The following is a description of a gene set: from publication Baranek T, Manh TP, Alexandre Y, Maqbool MA, Cabeza JZ, Tomasello E, Crozat K, Bessou G, Zucchini N, Robbins SH, Vivier E, Kalinke U, Ferrier P, Dalod M (PMID 23084923) studied in species Homo sapiens Human Gene Set: GSE39556_UNTREATED_VS_3H_POLYIC_INJ_MOUSE_NK_CELL_DN Genes down-regulated in NK cells: untreated versus poly(IC). The injection of the pathogen-associated molecular pattern Polyinosinic-polycytidylic acid (poly(I:C)) leads to the activation of various immune cells, including dendritic cells (DCs) and Natural Killer (NK) cells. This activation is due to different innate cytokines produced early after injection, in particular IFN-I. The objective of the study was to compare the pattern of expression of IFN-I stimulated genes between DC and NK cells. The project focused on a specific subset of conventional DC, CD8a DC, which responsiveness to IFN-I determines the capacity to activate CD8 T cells by cross-presentation of exogenous antigens. To identify the responses to IFN-I selectively induced in CD8a+ DC, we compared their gene expression profile to that of NK cells, using gene chips, before and after poly(I:C) stimulation., and this is the list of marker genes: CSNK1E, H2BC5, SOCS2, ATOSB, MYRF, OAS2, MED13L, H1-2, ITPR1, HLX, SERPING1, TTBK2, SPINK1, GNS, S1PR4, KRT12, STARD3, ZMYM2, HCP5, BAZ2B, RYBP, WASHC4, ATP2B4, ST3GAL6, SIAH2, TOGARAM1, RANBP6, PXDN, LILRB2 (leukocyte immunoglobulin like receptor B2), NPAS3, KLF10, MPPED2, ACSL1, CD99, CD34, KHNYN, HMCES, PSD3, CEP68, ERG, RFX5 (regulatory factor X5), YBX3, SV2A, PGLYRP1, IQGAP2, EIF1, FBLN5 (NCBI Gene Id 11268), FOXJ3, SORL1, MXI1 (MAX interactor 1, dimerization protein), WSB1, TNFAIP1, ITGA5, CTBS, SCARF1, SYNGR1, WDFY3, LST1, TSPAN7, CHST15, LIG4, PECAM1, N4BP2L2, PLSCR1 (NCBI Gene Id 5359), AP3S1, FOXO3, DEPP1, TRANK1, SNPH, ASB9, ZNF32, SERPINI1, AKAP12, RAPGEF2, CKMT2, MLXIP, STAT5A, OR7A5, MRPS14, CRIM1, GUCY1A1, AKT3, CHD1, VGLL4, LILRA2, MME, GNG11, ABLIM1, RIMS3, COBL, STAM, BMI1, KLF7, LRIG1, SERPINB6, AFF1, ACVR1, TSPAN9 (NCBI Gene Id 83441), WWP1, KIF3C, NEDD4, MPP1, SATB1, NRIP1, RETREG1, MRC2, NR3C1, CD9, RNASE2, MYB, CALCOCO2, NDRG1 (NCBI Gene Id 7998), DENND5A, NFYA, STX4, TMCC1, HOXA10, MTMR3, MAN1A1, ZNF135, SPIN2A, ARHGEF17, ZMIZ1, PTPN12, GADD45A, TLE1, GAB2, DMXL2, FPR1, CCN2, SMAD1, P2RY14, EDEM1, PLXNB2 (plexin B2), RECK, TNFAIP3, HERC4, TNFSF4, CSNK1A1, MAU2, H2BC21, PRMT2, ACTN1 (actinin alpha 1), RGL1, TKT, ANKRD17, SCHIP1, PPP3CC, SECISBP2L, RAG1, LMO2, FHIT, MEF2C, PDLIM7, DPYD, GABPB1, HOXA9, THEMIS2, SENP6, KCNS3 (NCBI Gene Id 3790), SUN2, H3C10, MMRN1, PDE4B (phosphodiesterase 4B), AK1, STK38, HIF1A, BRD1, CDS2, RAB11FIP5, MDK, SRSF5, AIF1, SLC2A5, CD27, TIA1, PTPRE, FAM30A (NCBI Gene Id 9834), ADA (adenosine deaminase), ENG, RABAC1, MYLK, SEC63, TMEM87A, LCP2, BRWD1, ROCK1, RDH11, H2AC6, CACNB3, PFN2, BCL11A, CCND2, GNAQ, RNF103, MAPK8IP3, ZFYVE16, GLS, UBL3, WFS1